Given this list of marker genes CFH, LMNA (lamin A/C), NOS3, STOX1, PPARG, CD46, HELLPAR, CFI, here is a description of the gene set: An acute and life-threatening complication of pregnancy, which is characterized by the appearance of tonic-clonic seizures, usually in a patient who had developed pre-eclampsia. Eclampsia includes seizures and coma that happen during pregnancy but are not due to preexisting or organic brain disorders. species: Homo sapiens Eclampsia Human Gene Set: HP_ECLAMPSIA